The following is a description of a gene set: species: Mus musculus Mouse Gene Set: GOMF_3_CHLOROALLYL_ALDEHYDE_DEHYDROGENASE_ACTIVITY Catalysis of the reaction: 3-chloroallyl aldehyde + H2O = 2 H+ + 2 e- + 3-chloroacrylic acid., and this is the list of marker genes: Aldh3a2, Aldh1a7, Aldh3b1, Aldh3b2, Aldh3a1, Aldh1a3, Aldh1a1, Aldh1a2, Aldh3b3